Given this list of marker genes RAMACL, SNRPD2, SNRPG, CMTR1, SNRPD1, SNRPD3, TGS1, SNRPE, SNRPF, SNRPB, RAMAC (NCBI Gene Id 91280), RNGTT, NCBP3, NCBP1, RNMT, CMTR2, here is a description of the gene set: The sequence of enzymatic reactions by which a cap structure is added to the 5' end of nascent RNA polymerase transcripts. Examples of RNA capping include 7-methyl-G caps found on all RNA polymerase II transcripts and nucleotide-containing cofactor caps, such as NAD(H) or FAD, found on bacterial trancripts. Human Gene Set: GOBP_RNA_CAPPING studied in species Homo sapiens